The following is a description of a gene set: studied in species Homo sapiens Human Gene Set: GOCC_INTAC_COMPLEX A protein complex containing Integrator and protein phosphatase 2A core enzyme (PP2A-AC) that stably associates with the C-terminus of RNA polymerase II and promotes premature RNA polymerase II transcription termination., and this is the list of marker genes: INTS13, INTS10, INTS9, INTS2, INTS1, INTS12, INTS7, INTS3, INTS14, PPP2CA, INTS6, PPP2R1A, INTS8, INTS4, INTS11, INTS15, INTS5